Given this list of marker genes EXOC5, EXOC6, EXOC1, EXOC4, EXOC6B, EXOC7, EXOC8 (NCBI Gene Id 149371), EXOC3, EXOC2, here is a description of the gene set: The initial, indirect interaction between a secretory vesicle membrane and a site of exocytosis in the plasma membrane. This interaction is mediated by tethering factors (or complexes), which interact with both membranes. Interaction can occur via direct binding to membrane phospholipids or membrane proteins, or via binding to vesicle coat proteins. This process is distinct from and prior to docking and fusion. Human Gene Set: GOBP_VESICLE_TETHERING_INVOLVED_IN_EXOCYTOSIS species: Homo sapiens